The following is a description of a gene set: species: Mus musculus Mouse Gene Set: REACTOME_PHYSIOLOGICAL_FACTORS Physiological factors, and this is the list of marker genes: Mme, Ces1d, Npr2, Nppa, Npr1, Corin, Nppc